The following is a description of a gene set: studied in species Homo sapiens Human Gene Set: ATGTAGC_MIR221_MIR222 Genes having at least one occurence of the motif ATGTAGC in their 3' untranslated region. The motif represents putative target (that is, seed match) of human mature miRNAs hsa-miR-221 and hsa-miR-222 (v7.1 miRBase)., and this is the list of marker genes: PCDHA6, IGF2BP2, HECTD2, UBE2J1, PAIP2, DACH1, PCDHA8 (NCBI Gene Id 56140), CBFB, RSBN1L, PCDHA7, DYRK1A, NSMCE4A, ZNF385A, PCDHA12, GNAI2, ARID1A, ETS2, CASZ1, PCDHA13, MIDN, FAT2, TLNRD1, FNDC3A, SUN2, INA, NAA25, TMCC1, PTGR3, PCDHA11, PLPPR1, HIPK1, PPARGC1A, DCAF12, TRPS1, RALA, HMGCLL1, MYLIP, VEZF1, ANKHD1, SBK1, ESR1, TIMP3, ATOSA, PURA, SLC25A37, NRK, FMR1, CREBZF, C3orf70, RIMS3, OGT, DNAJC14, PCDHA5, RAB1A, MAP3K10, PKDCC, KIF16B, LRFN2, DMRT3, MYO10, VASH1, IRX5, FOXN2, PCDHA2, SHTN1, AGFG1, CDKN1C, SYBU, KLC1, VAPB, IRF2, KANSL1, MIER3, BMF, CDK19, KMT2A, QKI, PHF2, AXIN2, NTF3, FERMT2, SNCB, YWHAG, BICDL1, EIF4E3, PCDHA10, HOXC10, OSBPL7, ADAM11, INSIG1, MSL2, PCDHAC1, PPP6C, CDKN1B, PCDHA4, CDV3, ATXN1, SEMA6D, FOS, MAPK10, ZFPM2 (NCBI Gene Id 56958), PCDHA9, RALGAPA1, PPP3R1, ZEB2, PAK1, PCDHA3, PDCD10, POGZ, ETS1, ARF4, ACACA, KSR1, ARNT (NCBI Gene Id 405), ASB7, TOX, CD4, LIFR, EIF3J, RBM24, NAP1L5, ANGPTL2 (NCBI Gene Id 23452), VGLL4, FAM13A, CPNE8, ATP1A1 (NCBI Gene Id 476), NLK, SHANK2, MEIS1, PAIP1, KHDRBS2, NOVA1, CLVS2, PCDHA1, CTCF, PCDHAC2, EIF5A2, AMMECR1, DCUN1D1, TCF12